The following is a description of a gene set: from publication Kaji T, Ishige A, Hikida M, Taka J, Hijikata A, Kubo M, Nagashima T, Takahashi Y, Kurosaki T, Okada M, Ohara O, Rajewsky K, Takemori T (PMID 23027924) To obtain insight into the genetic basis of the increase of functional activity of memory B cells over time, we compared the gene expression profiles of day 7 and day 40 NP-specific/IgG1 memory B cells, GC B cells and plasma cells in immunized WT mice and naïve B cells, before and after activation in vitro. studied in species Homo sapiens Genes down-regulated in follicular B cells versus day 7 plasma cells. Human Gene Set: GSE11961_FOLLICULAR_BCELL_VS_PLASMA_CELL_DAY7_DN, and this is the list of marker genes: MTERF1, TNFSF14 (NCBI Gene Id 94566), LEF1, CDIN1, PPIG, PPP3CC, ABHD14B, OVGP1, SLA2 (NCBI Gene Id 84174), HERC2, ANGPTL4 (NCBI Gene Id 93954), KMT2E, WDR82, KRT6A, EML3, ST7, AMACR (NCBI Gene Id 23600), IL7R, ZNF143 (NCBI Gene Id 7702), ARHGAP9, SERPINE2, CYP17A1, EMID1, TMEM238L, NASP, TEDC1, PXYLP1, TCF12, SPINK1, MTMR9, ABCA2, WDHD1, IQGAP2, SNX7, BCL7B, ZNF579, NAA38, ALKBH4, IFIT2, NCK1, KCTD15, GSAP, CYB5R2, SUSD1, IKZF1, CD96, SASH3, LRIG2, FBXL2, ANKRD28, MED4, GALNTL5, S100A10, APOBEC2, PTPN4, TPST2, RTF1, KLRK1, MYLIP, ITGB2, MOSMO, RNF138 (ring finger protein 138), WDR26, ZDHHC20, FUT11, SEMA4A, ETS1, RABIF, PRPSAP1, LIMK2, KRAS, USP37, IPO11, INO80D, ANKRD44, PHF20, CCSER2, DEF6, PAM, ATP2A3, DMRT2, MMRN2, GAB3, EPSTI1, AGO1, OSBPL5, TRIM8 (tripartite motif containing 8), ARG1, ULK1, P3H4, MTURN, PRKAG1, POGZ, VPS4B, PXMP2, CSNK1G1, KLHDC2, DYRK2, BORCS7, TCOF1, KATNBL1, TRIM56, YPEL1, PAFAH1B2, RORA, ELAVL1, CISD3, NXNL2, PDE3B, PTK2B, AFP, DGKA, FAM184A, PADI4, LAMTOR3, TECPR1, CAPN2, PDP1, HELZ2, DDX47, ADGRG3, NFATC1, ORMDL1, MED20, SRCAP, PLGRKT, YPEL3, SORD, TTC39C, UBASH3A, HMGXB4, GIGYF2, EPC2, RAI1, SNX33 (NCBI Gene Id 257364), AUH, GNPTG, TBL2, ERCC4, NR0B1, COL4A3, ABCB10, OSBPL3, KCNAB2, NOP10, NR3C1, RHOC, NPRL2, PRKCH, EPC1, POLR3GL, MYL4, NEFH, NRIP1, MFAP1, HAUS3, ZC3HAV1, ITGA2, TLK1, CHST11, BMS1, ASB13, KAT14, SLC16A10, ZPBP2 (NCBI Gene Id 124626), RNF220, FOXO1, DENND11, DUSP5, TIMM8A (NCBI Gene Id 84782), GAS2, TRAF3IP1, CHL1, KCNIP3 (potassium voltage-gated channel interacting protein 3), FHL2, CETN2, NSD3, TRMT10B, ADAM10, BRD9, GIN1, ATP2B1, UROD (uroporphyrinogen decarboxylase), PON2, GPR87, CLDN12, CCDC88C, RAD51C, TMEM241, TASL, RBM15B, ITSN2, SKOR1, TMEM9, SMC3, MKLN1, PDK4, PARD6G, SLC20A1 (solute carrier family 20 member 1), CNOT1